Given this list of marker genes Shfl, Etf1, Gspt1, Ogfod1, Jmjd4, Upf1, Eif5a, Eif5a2, here is a description of the gene set: studied in species Mus musculus Any process that modulates the frequency, rate or extent of translational termination. Mouse Gene Set: GOBP_REGULATION_OF_TRANSLATIONAL_TERMINATION